Given this list of marker genes CHD7, RNU7-1, C12orf57, CNTNAP2, TAF4, DPYD, HPRT1, TMCO1, MADD (NCBI Gene Id 8567), NTRK1, EP300, BCOR, CTNNB1, RAI1, HERC2, PAH, SMG8, GRM7, CLTCL1, TREX1, AUH, TRIO, THOC2, GRIA3, SLC6A8, TMEM231, NAT8L, SLC6A17, ALG13, WDR62, H4C5, CAMK2G, DHCR7, EHMT1, HDC, VPS13A, ASL, GATAD2B, LARP7, ADSL, NAA10, INPP5E, OPHN1, CREBBP, TTI1, NDE1 (nudE neurodevelopment protein 1), SLITRK1, MGAT2, SATB2, SYT1, MYT1L, ATG7, here is a description of the gene set: species: Homo sapiens Human Gene Set: HP_SELF_MUTILATION Self-mutilation Deliberate harm to one's body resulting in tissue damage, without a conscious intent to die.